The following is a description of a gene set: Genes down-regulated in comparison of dendritic cells (DC) stimulated with R848 at 2 h versus DCs stimulatd with R848 for 8 h. species: Homo sapiens Human Gene Set: GSE2706_2H_VS_8H_R848_STIM_DC_DN Toll like receptors (TLRs) sense microbial products and initiate adaptive immune responses by activating dendritic cells (DCs). Since pathogens may contain several agonists we asked whether different TLRs may synergize in DC activation. We report that in human and mouse DC TLR3 or TLR4 potently synergize with TLR7, TLR8 or TLR9 in the induction of selected cytokine genes. Upon synergistic stimulation, IL-12, IL-23 and Delta-4 are induced at levels 50-100 fold higher than those induced by optimal concentrations of single agonists, leading to enhanced and sustained TH1 polarizing capacity. Using microarray analysis we show that only 1.5% of the transcripts induced by single TLR agonists are synergistically regulated by combinations of TLR4 and TLR8 agonists. These results identify a combinatorial code by which DCs discriminate pathogens and provide (suggest) a rationale to design adjuvants for TH1 responses. Series_overall_design: 3 untreated, 3 treated with LPS at 2h, 3 treated with LPS at 8h, 3 treated with R848 at 2h, 3 treated with R848 at 8h, 3 treated with LPS + R848 at 2h, 3 treated with LPS + R848 at 8h from publication Napolitani G, Rinaldi A, Bertoni F, Sallusto F, Lanzavecchia A (PMID 15995707), and this is the list of marker genes: SERPING1, FSD1L, RSU1P2, FRMD3, SYCP1 (NCBI Gene Id 6847), BCL2L11, ATXN7L2, TMEM79, GNG8, TSC22D1-AS1, BET1, ARFGAP3 (ADP ribosylation factor GTPase activating protein 3), CCL7, CYP3A5, GUCY1B1 (NCBI Gene Id 2983), PSAT1, KLHL12, SAMD9L, HSD11B1, PCDHB11, PNPT1, TBC1D4, CD86, IGSF3, UBE2L6, GVINP1, SP110, XIAP, DOCK4, STAT1, FPR2, TMEM255A, SHROOM2, HAPLN3, MAP4K5 (NCBI Gene Id 11183), SLC22A24, IFI16, ETV5, TXN, MACC1 (NCBI Gene Id 346389), TSPEAR, WDR5B, TNS3, SCYL3, TNFSF4, KCNE1, MROCKI, WARS1, ITGB8, CES1, TIMM29, TSHB, AK8, NIPSNAP3B (NCBI Gene Id 55335), GIMAP8, APAF1, PIK3CA, DDX60, OAS2, PRKAG2, PARP9, ALDH1A2, PDILT, COBLL1, CUL1, CYTIP, SPART, DNAJC9-AS1, BTG1, IFI44, SOWAHC, PIR, L3MBTL3, CCL25, ARHGAP24, INPP5F, GPR18, TCEANC2, HMGN3, PGAP1, BRIP1, DRD1, LMNB1, LIFR-AS1, NOPCHAP1, TRIM22, MAML2, APOBEC3G, GOLGA5, CYRIA, PRR22, IL12A (interleukin 12A), DYNLT1, TGFA, LAP3, XAF1, SUN5, FBXO5 (NCBI Gene Id 26271), IFI35, TNIP3, LINC00158, ART4, CMPK2, CREBRF, LRRIQ1, TLX3, TRAFD1 (NCBI Gene Id 10906), NT5C3A, USP15, OR6B1, ASNS (NCBI Gene Id 440), SOS1, HERC5, ZNF667, DTX3L, EPSTI1, TARP, CRACD, CMTR1, DUSP4, SLC7A11, BRWD3, ACSL4, CXCL6, XRN1, CCDC71L, CASP7, SLC1A2, SLC5A9, PLA2G4A, THBS1, PRR5L, UBA6, PARP14, TTPAL, CCR7, TMPO-AS1, SSB, TDRD7 (tudor domain containing 7), KLHL6 (kelch like family member 6), RIT2, CHMP5, IFI6, TRIM5, FEZ1, SH3GL2, RIGI, CRLF2, MMP10, VMO1, VNN2, ITCH, MMP7, RDX (NCBI Gene Id 5962), ARHGAP25, IFI44L, FAM110B, JADE1, LILRA3, SMAD4, IL7, CBLIF, NMI, HOXC6, TMCO1-AS1, SLFN12, NCR1, TFPI, SLC31A1, CYP19A1, JAK2 (Janus kinase 2), EPYC, FAAH2, EIF2AK2, SSX5, C3orf38 (NCBI Gene Id 285237), LILRA5, TBC1D8, STK4, EWSAT1, USP25, TNFSF15, PLOD2, SEMA3C, WASL, ADA, SOX4, STAT2, LARGE-AS1, TIA1, NCK2, CDC73, GBP1, TNFSF10, CTLA4, RAB10